Given this list of marker genes RPRD2, ATAD1, GRAPL, CFLAR, SYNJ2BP-COX16, MTCL2, CBX3, DIP2B, LARP1B, TLCD5, GABRA3, PAPOLG, ZNF671, SH3RF1, PBXIP1, MAP3K1, PENK, POTEF, DOCK5, VASP, TRAPPC3, PAFAH1B1, SP7, ETV5, ZNF143, WDFY3, ARMC1, PPP6C, TXNIP, LPCAT2, SLC35F1, LCOR, AFDN, PCDH15, DDX41, ARHGAP36, RHOA, TRPC5, CDC42EP1, VANGL2, BPIFA3, INA, NOVA1, C1orf115, JADE3, BBS9, NCR3LG1, USP38, DSE, AASDHPPT, RIC8B, DMGDH, RAB27B, MINDY3, SH3PXD2B, HOMER1, MUC15, COX16, here is a description of the gene set: from publication Chen Y, Wang X (PMID 31504780) Human Gene Set: MIR6881_5P studied in species Homo sapiens Genes predicted to be targets of miRBase v22 microRNA hsa-miR-6881-5p in miRDB v6.0 with MirTarget v4 prediction scores > 80 (high confidence targets).